The following is a description of a gene set: Mouse Gene Set: GOBP_NEGATIVE_REGULATION_OF_SPHINGOLIPID_BIOSYNTHETIC_PROCESS Any process that decreases the rate, frequency or extent of sphingolipid biosynthesis. Sphingolipid biosynthesis is the chemical reactions and pathways resulting in the formation of sphingolipids, any of a class of lipids containing the long-chain amine diol sphingosine or a closely related base (a sphingoid). studied in species Mus musculus, and this is the list of marker genes: Ormdl1, Atg7, Abca2, Ormdl2, Sphk1, Ormdl3 (NCBI Gene Id 66612)